Given this list of marker genes SPP1, STAT1, FASLG, SAT1, IRAK1, DEF6, CASP10, PRKCD, FAS, DNASE1, PTPN22, STING1, STAT4, FCGR2A, ADA2, CTLA4, FCGR2B, TREX1, here is a description of the gene set: Human Gene Set: HP_ANTIPHOSPHOLIPID_ANTIBODY_POSITIVITY Antiphospholipid antibody positivity studied in species Homo sapiens The presence of circulating autoantibodies to phospholipids.